The following is a description of a gene set: HGF-MET-PI3K signaling pathway. Pathway ID: N00043. Pathway type: Reference. Pathway class: nt06261 Gastric cancer. Pathway Definition from KEGG: HGF -> MET -> GAB1 -> PI3K -> PIP3 -> AKT -| BAD species: Homo sapiens Human Gene Set: KEGG_MEDICUS_REFERENCE_HGF_MET_PI3K_SIGNALING_PATHWAY, and this is the list of marker genes: MET, AKT2, PIK3CD, AKT1, PIK3CB (phosphatidylinositol-4,5-bisphosphate 3-kinase catalytic subunit beta), HGF, PIK3CA, GAB1, BAD, AKT3